Given this list of marker genes LAMA2, MAN1A1, SLC35F1, RNF146, COL10A1, TRMT11, ENSG00000289376, MTCL3, RN7SKP18, BRD7P3, RNU6-214P, RSPH4A, ATP5MGP2 (ATP synthase membrane subunit g pseudogene 2), RPL5P21, SERINC1, ROS1, FAM184A, TMEM244, NEPNP (nephrocan, pseudogene), NIP7P3, CALHM6-AS1, FAM162B, LNCPOIR, RPL13AP15, GJA1, RNF217-AS1, MIR548B, RAP1BP3, HS3ST5, LINC02523, CEP85L, DNAJA1P4, ENSG00000310237, SLC25A5P7, RPL23AP48, PPP1R14BP5, CENPW, RNU6-475P (NCBI Gene Id 106479776), NT5DC1, DCBLD1, MIR588, RNA5SP213, RPS29P13, GPRC6A (NCBI Gene Id 222545), SMPDL3A, RNU1-18P, ECHDC1, TRAPPC3L, HEY2, CBX3P9, RNU4-35P, PTPRK, TRDN-AS1, RN7SL564P, MCM9, RNU6-200P, RPL21P64, MESTP1, SELENOKP3, ENSG00000226409, TPI1P3, TSPYL1, ARHGAP18, RNA5SP214, HDDC2, RPL17P23, THEMIS, TPD52L1, LINC02534, COX6A1P3, PTPRK-AS1, ASF1A, ENSG00000287097, NKAIN2, ENSG00000287258, MRPS17P5, PKIB, RNU6-1286P, RNA5SP217, PLN, B3GALNT2P1, RNU2-8P, CLVS2, FRK, MIR3144, HMGB3P18, RNU6-861P, SSXP10, RPL5P18, GOPC, KPNA5, RNU4-76P, NCOA7, TSPYL4 (TSPY like 4), YWHAZP4, C6orf58, RNA5SP216, LINC02536, ENSG00000286339, BMPR1AP1, CALHM5, RNU6-194P, KIAA0408, KRT18P22, RNA5SP215, YAP1P3, RFX6 (regulatory factor X6), RN7SKP56, ZUP1, TBC1D32, DSE, RWDD1 (RWD domain containing 1), EEF1DP5, PRELID1P1, NCOA7-AS1, RNF217, RN7SKP51, NUS1, RPS4XP9, HSF2, FABP7, VGLL2, RSPO3, CALHM4, TRDN, HINT3, RNU6-253P, RPL29P4, CALHM6, HEY2-AS1, here is a description of the gene set: species: Homo sapiens Human Gene Set: chr6q22